The following is a description of a gene set: Human Gene Set: SFMBT1_TARGET_GENES Genes containing one or more binding sites for (SFMBT1) in their promoter regions (TSS -1000,+100 bp) as identified by GTRD version 20.06 ChIP-seq harmonization. species: Homo sapiens from publication Yevshin I, Sharipov R, Kolmykov S, Kondrakhin Y, Kolpakov F (PMID 30445619), and this is the list of marker genes: ENSG00000267174, SRP54-AS1, ACAD9, NARF, SPART, MMRN2, MTCL2, UCKL1, UCP2, NR2F1, AHCTF1, CERS5, ADD3-AS1, ATPAF2, NDUFS7, MDM2, DDIT4, DHRS13, RASSF8-AS1, SBF2, PTP4A1, TTC9C, ATF7-NPFF, PPP2R5E, GEMIN8P4, CLK3, IFT74, CACNA1A, TRIM27, PIP5K1A, EIF4G2, TNPO1, WDR25, NFKBIA (NFKB inhibitor alpha), DTX3L, AGPAT1 (1-acylglycerol-3-phosphate O-acyltransferase 1), VTI1B, SNORA50C, FRG1HP, FANCA (FA complementation group A), HIVEP1, TWSG1-DT, SNORA78, GLI3, TANGO6 (NCBI Gene Id 79613), GABPB1, GAN, PUM1, C2CD3, NTPCR, HSPA1L, AKAP9, HSPA1A, ZBTB21, PCNT, STK10, DIP2A, SNRPA1, ATP8B1-AS1, CRYZL2P-SEC16B, EPN1, COX5A, TMEM250, PYCR2, PIERCE2, UACA, RALGPS1, LINC01931, ALKBH5, BLOC1S5-TXNDC5, IST1, HDHD5-AS1, LUC7L2, COA4, CCPG1, STX18-AS1, CCNK, USP9X, UBC, BBS4 (NCBI Gene Id 585), AJUBA, MAP4K5, ASB7, NPHP3, CTSS, TNRC18, AP3B1, SIGLEC20P, FUT11, PPOX, KMT5B, PKN2, ZNF75D, PCF11, CDKN1B, MRPL54, VPS13D, SLC25A36, DHRS3, TCF12, MRPS15, ZNRF2, PPFIA2, CLDN7, SPRY2, ARL6IP1, ORAI1, LINC01600, EXD3, SLC35G2, HIF3A, PKM, RIF1, LAMTOR5-AS1, NFS1, ISG20, ZNF503-AS2 (NCBI Gene Id 283065), PALS1, FIRRM, WWTR1, HSPA5-DT, LINC01089, MID1IP1, TIA1, SELENOS, SNX30-DT, VAV2, IL6R, FRA10AC1, C14orf93, SVIL-AS1, ATXN7, PARD6A, GTPBP3, PRKCD, SF3B2, RPLP2, HINT3, GNPNAT1, SNORD95, FREM2, SMNDC1, PFKM, SON, MAU2, ATL1, OTULIN-DT, SPEN, AGAP2-AS1, ZFP91-CNTF, SEC61G, BLOC1S5, ZNF213-AS1, ANXA2, HINT1, MBD2, NR4A2, HOXC9, RCOR3, ENTR1, RN7SL329P, ZNF143-AS1, NDUFV3, KANSL2, NEO1, TMEM50B, SND1-DT (NCBI Gene Id 121832805), PIKFYVE, ENSG00000272473, VPS51, ZNF688, MAF1, IPMK, PHIP, SRP54, ITCH-AS1, ZBTB20, XPA, PDXK, TRIM23, GATAD2B, VAPA, KIF22, CSNK1G3, ZC3H7A, FRAT1, HEATR5A, AKR1C3, ARHGEF37, ZSWIM6, GSE1, NFE2L1, KCTD15, RAPGEF3 (NCBI Gene Id 27105), CT62, YIPF6, NSUN3, FAM228B, SNORD114-18, BEND6, PSMD9, STX16-NPEPL1, CCDC18, FEM1A, ECE1, PLEKHB2, ZRANB3, GFUS, LINS1, YY1AP1, HNRNPUL2-BSCL2, CDCA2, WASF1, NDUFB2, DLD, PDK1, SNORA48, SEC14L1, JPX, HSP90AA1, ABCC5-AS1 (NCBI Gene Id 100873982), SNORD35B, ENSG00000232732, SFR1, BANF1, DMXL2, MTARC1, CXXC5-AS1, EMBP1, POR, FOXP4-AS1, WDR4, CYREN, PHGDH, CARS2, NHLRC3, MFHAS1, SERP1, ARL2BP, TDRKH-AS1, TRIM2, THAP7, SQLE, COX6B1, DOLK, TIMM44, ELAC1, FOXP4, SLC35G1, ERBB3, CNOT10, SLC29A2, PIAS1, MFSD4B-DT, AQP3, SNHG15, TFB2M, SPTBN1, DPP8, RHOBTB1, SLC39A13, ZFAND3-DT, PON3, TMEM44, DOK1, DSCC1, RCCD1-AS1, SLC22A4, AP3B2, TPGS1, CDCA4, POLH, NFIA, INTS5, CIPC, SERPINB8, CPSF3, SERINC4, CKAP5, MAGI2, SSBP1, AKAP17A, PMF1 (NCBI Gene Id 94958), BCAN-AS2, ITGB3BP, PUS7, RIMKLB, ALG5, AFF4, PAAF1, SAAL1, TMED2, LINC03014, SYNM-AS1, THAP12, TGFB1I1, ATP1A1, RPL18A, DDX42, MFSD4B, ESRP2, VAC14, SMPDL3A, PARP1, ST20-MTHFS, EIF1B, DDAH2, SAPCD2, YTHDF2, TNPO1-DT, ASPSCR1, ERBB2, DNAJC13, PHF21A, SF3A3, XKR9, CCDC6, TMEM127, TMCC2, ECE2, CASP6, DNAJB14, PAN2, ARL6IP4, FBXO44, NEMP2-DT, ZNF142, FKBP7, LIN54, FURIN, RBM12B-DT, SNRPA1-DT, RGS3, KCNK15-AS1, SHTN1, FCHSD2, IL5, H1-4, THSD4, DDB1, USP47, WDR53, MRPL51, LINC01547, SQLE-DT, PSMB9, CEBPG, PIK3IP1-DT, LIPT2, ALKBH4, GFI1B, BRD4 (NCBI Gene Id 90616), MCL1, CFAP184, BLTP1, STARD7, CCDC97, MRPL38, TAX1BP1-AS1, ITGB5, PTPN9, AHNAK, GOLM2, TSEN15, ANKRD13A, SP4, SLC2A3P1, LCN8, NAXE, TTLL11, CAPRIN1, ACAP3, GOLGA4 (NCBI Gene Id 2803), NFE2L1-DT, VIM, CHERP, GALNT16-AS1, PBX3, CAP2, POLR1G, THOC1, SIAH2, CAPZB, IL23A (interleukin 23 subunit alpha), ASAP2, BNIP2, ATF6-DT, TFAM, TBC1D14, DHX16, PDCD4, SLX4IP, DNAL1, PWWP2A, PDE2A-AS1, UNC45A, EXTL2, MTBP, BRD3OS (NCBI Gene Id 266655), ADGRL1-AS1, TRMT11, OR4C10P, DOCK4, ADPGK, RNU6-942P, TP53BP2, MRPS2, SNX12, GNAL, FAM186A, ZFP91, MRPS23, CYP51A1, FBXL16, ART3, PPP2CA-DT, PDGFA, NUCKS1, LINC03015, OAZ1, NUDCD2, MICB, CTCF, NXF1, RPL5P34, TRAPPC13, FLAD1, SNHG7, SPTLC2, FAM217A, TANC1, SNHG9, ADRM1, FAM50B, PDCD6P1, ENSG00000273145, MEX3B, CROCC, MRPL17, FBXO9, SERTAD4-AS1, AK1, DTNB, EXOC2, CNOT1, ADM, PABIR1, PBX3-DT, INO80B, SLC9A3R1-AS1, CLNS1A, ZSCAN21, HYCC2, EPB41, YAP1, RNA5SP146, SGSM1, MBTD1, NDUFB5, ADAP2, DEFB1, SLC4A2, SNHG5, RPS26, ZNF326, ATG5, WDR11 (NCBI Gene Id 79207), CHSY1, HARS1, ETF1, CHD3, SETD4, SMAD3-DT, KCTD10, NDUFA8, CABLES1, MED10, HMGB1, LYPD8, TROAP, ADCY6-DT, NOXA1, PLIN3, ITPR1 (NCBI Gene Id 619543), SNORA40, NLRP11, MACF1, TOR1AIP1, GTF3C4, KLF2-DT, ING1, NAPEPLD, DNM1, FUT10, ELOF1, ADAMTS1, SORBS1, UBE2L5, RIOX1, CD55, KLHDC10, SNX33, VSIG10, MRPS30 (NCBI Gene Id 51331), SPRED1, HNRNPUL2, MSH5, VPS13C-DT, ZXDB, RANBP9, CEP63, HOXA6, CCNYL1, NUDT3, SSX2IP, NPL, PEX3, SNX30, HIPK3, TIPIN, LONRF3, DUOX1, ITFG1-AS1, TSR2, LINC01703, ZGPAT, KLHL24, CIZ1, GON7, PGAM5, ANTKMT, WDR36, NCK1-DT, TLK1, RICTOR, GALNT10, RGS6, SUMO2P20, ZNF436, ZC3H6, UBE2D3-AS1, EIF2D (NCBI Gene Id 1939), PCAT6, RAD9A, DGCR8, TOP3A, ADAT2, TTC33, CCDC57, NDUFAF6, GABPB1-AS1, PDCD6IP, F11R, EHBP1, ABCB9, EBP, ANKS1A, GVQW3, PPIC, SUN2, PPP1R13L, GABPB2, SEMA3A, MPHOSPH10, RAD51AP1, LRP6, GART, INTS1, SLC1A4, MAPK6-DT, CDC40, KCTD9 (potassium channel tetramerization domain containing 9), LIFR, IKBKB-DT, SERPINB6, LRP8-DT, ANP32E, EFCAB7 (EF-hand calcium binding domain 7), RHOV (NCBI Gene Id 171177), DDX31, HECW2, ANAPC13, TADA2B, POLR1F, AQP5, SEC23IP, DPY19L1, CYP39A1, EFNA1, ENO3, TCTN3, EXTL3, PIK3IP1, CBX3, MYO5A, OPHN1, C6orf62, TIGIT, YWHAQ, TMEM41B, ANGEL2, SKA2, ZNF131, SETD5 (SET domain containing 5), TUBGCP5, HPS5, SIX2, TLL1, SULT1A1, MLXIPL (NCBI Gene Id 51085), JAKMIP2, ATF7, DYRK3-AS1, PPP5D1P, C2CD2L, RN7SL197P, YARS1, KLRG1, CALML4, CUL4A, ZFPL1, E2F8, TBC1D13 (NCBI Gene Id 54662), SPHK1, PHTF2, ZFP36, CSNK1A1L, ZBTB9, DCXR, CLIC1, NUP214, MIR31, MIRLET7IHG, ZNF160, SH3RF2, LINC00857, NSUN2, WDR35, CCDC88A, FBXW11, UGGT1, TAF11, RFX7, MRPS7, CDKN1C, POLR1H, ABCD4, UNC5B, LINC01836, SLX9, ALAS1, GMEB2, APBA3, CAV1, KANSL1, SYNM, AGO3, TP53I3, ID3, LINC02084, SUGCT, RSRC1, NEPNP, ATP1B1, ENSG00000237773, NUP188, BMF, SERPINI2, PTEN, PTBP1, METTL16, VGLL4, STT3B, CCNO-DT, CCDC32, PACSIN3, METTL8, MRPL55, CAPZA1, TACO1, HMMR, E4F1, TMPPE, NETO2, FAM98B, PLAG1, FOXJ3, ENDOV, KPNB1-DT, DNTTIP2, MOV10, INHBA, PFN2, ANTXR1, GRAMD4, S100A16, GGA3, EIF4ENIF1, AURKAIP1, ZNF277, WDR35-DT, NSMAF, SNHG25, TINAGL1, NPR3, EIF4A2, FERRY3, RPS2, AJUBA-DT, TMCO1, FASTKD3, TMTC3, RNF207-AS1, FZD10-AS1, PPME1, RNU7-13P, BOLA3-DT, HNRNPF, MUS81, MEIS1 (Meis homeobox 1), CDK5, H2AC20, DHFR2, ZNF451, GTF3C3, ZNRF2P1 (NCBI Gene Id 441208), RPUSD2, KANSL1-AS1, UBE2D2, CMSS1, PRKCZ, SEPTIN2, GATA6, SLTM, FSCN1, GEMIN8, UROS, ANAPC5, LINC01588, PIR, MAP3K3, EIF1B-AS1, CTNNB1, RAB14, AMACR, DUSP5, GALE, BHLHE40, ANAPC11, DHCR24-DT, CACYBP, HUS1, MIR4512, CGGBP1, SLCO4A1-AS1, RNF4, HGSNAT, VDAC1 (NCBI Gene Id 7416), CDC42EP4, PUS1, OSGIN2, MUCL3, SYNGAP1-AS1, SLC25A27, CSTF3-DT, GINS3, COTL1, MT2A, MCFD2, SOX7-AS1, CHD2, UTP14A, DHFRP2, HCFC1R1, MID1IP1-AS1, HNRNPLL, SNRPE, COMMD6, FKBP8, USP3, SS18L2, TPMT, ADNP (activity dependent neuroprotector homeobox, NCBI Gene Id 256440), SUGP1, ATL3, RACK1, HSPA5, PGBD2, H2AZ2-DT, ARPC5L, SLC2A4RG, H1-10, ZFAT, GUCD1, UAP1-DT, CTNNBL1, SLC25A39, ABLIM3, ZFAND6, SLC7A6, FAM162A, CNOT7, RN7SL862P, SIN3A (NCBI Gene Id 25942), MIR3137, ADCY7, PI4K2A, ZMPSTE24, POLD3, FZD10, WNT2B, TMC1, PER1, POLR3B, ZNF639, GLB1, CCNE2, CACTIN, GTF2H1, SMAD3, ARHGAP5-AS1, CHCHD7, MTHFD2L, EIF5B, FAM3C, H2BC4, RNU6-21P, TNFSF13, ARHGAP28-AS1, SLC39A14, SCAMP1, DNA2 (DNA replication helicase/nuclease 2), HADH, SECISBP2L, PPP2R5A, CALM1, TMCO4, ZC3H12A, UBR7, NFIB, HOXA13, ABCA2, RRM2, ZIC2, MIR17HG, STARD4, RBIS, RPS7, DAXX (death domain associated protein), SLMAP (NCBI Gene Id 7871), C2orf76, TMEM170A, CYP4F3, WWTR1-AS1, SCAF4, TRIM52, STX16, MSLN, POFUT1, TMX3, ST6GALNAC2, COMMD2, COL4A3, SH3BGRL3, HMOX1, GK5, OSCP1, PHF8, MAPK1IP1L, ST7L, RBM12B, CD2BP2, MIR3661, GTF2I, SERTAD1, DPY19L4, OGT, ARHGAP21 (NCBI Gene Id 57584), KLHL20, HIGD1AP5, ARL2, RBPJ, LEMD2, ZCCHC2, TDRKH, CALU, XK, RNU7-152P, HIRA, ZBTB49, CDH3, APAF1, NIPAL1, FUNDC1, MAIP1, HEATR5A-DT, ENSG00000254718, SUN1, WWC2, PEAK1, MIX23, ZFAND3 (zinc finger AN1-type containing 3), C16orf95-DT, DCXR-DT, API5, SLC39A3, TNC, CISD1, LZIC, MPV17, MEMO1, SYP, LDB1, CLP1, DAP3, GAA (alpha glucosidase), LSR, NUCB2, PDE3A-AS1, SHLD3, CYP4V2, LPXN, NELFA, TFAP4, ELP6, ARB2A, TCF25, UBAP2L, TRIO, ETV5, TRMO, TAF15, TSC1, NEDD1, ZNF367, TICAM1, FOXC2, HMGXB3, RBP4, PIERCE1, VGF, IMP4, SDCCAG8, MRAS, WDR11-DT, H4C16, TPM2, C1GALT1P1, SLC27A3, APBB3, ASF1B, TRIM47, BCAR3, NPR1, CENPBD2P, C9orf78, TADA2A, HSD17B1-AS1, GATM, SARAF, SNX9, SNAPIN, LRRC1, AGPAT3, MUC19, THUMPD3-AS1, EHD4, OXCT1-AS1, IDH1, RIMOC1, RNF207, ALYREF, HNRNPH3, KLHL29, BRPF1, MAGEF1, DOP1A, ATF6, RBM39, TMEM222, MPI, EXOC3-AS1, MIR5585, FHL1, EGR1, BRWD1, RLIG1, UBE2Q2, SRP9, GAPDH, ZDHHC16, NAA15, ID2, ACAA2, STAT5A, LINC01686, SS18, RPL35, XPO7 (exportin 7), PDZD2, ATP5MGP8, NOD1, UTP18, KYAT1, HTR1A, NCOA4, PLCXD2, MRPL40, YWHAZ, DUSP5-DT, PSMC3, RGL1, GAPDH-DT, GMNN, RAB10, INHBA-AS1, ARHGAP5, IKBKB, HNRNPR, ALDH3B1, NARF-AS2, LSM6, CBLL1 (NCBI Gene Id 79872), TCHP, RXRA, CCDC102B, BICD2, SMG7, THRB-AS1, PCDH9, FAM136A, ZMPSTE24-DT, EMP1, DST, CEP290, MIR4289, EXD2 (NCBI Gene Id 55218), SNAPC5, MGA, CASP2, ZNF205, SND1, GPNMB, KAZALD1, FLJ38576, ENSG00000266401, MED25, CDH6, C5orf22, CNN2 (NCBI Gene Id 1265), VAV3-AS1, RINT1, ID2-AS1, ARFRP1, SOAT1, SLC38A1, RAB11FIP3, ANKRD46, ALG3 (ALG3 alpha-1,3- mannosyltransferase), MCEE, ALG10B, MCAM, MOGS, TAF13, CIMAP1B, ATG12, TM2D3, DONSON, TFAP2A, ARL3, NDUFC2, ARHGEF2, TMEM179B, CD2BP2-DT (NCBI Gene Id 101928707), ATP2B1-AS1, DRAM1, ANXA2R-AS1, WDR45B, ZNF627, DPP9, ASAH2B, SLC45A4, WARS1 (NCBI Gene Id 7453), P2RY6, TNIK, FBF1, SMAD6, OARD1, NDUFC2-KCTD14, DPYSL2, SNORD12C, TTC24, KPNB1, KIF1B, CCDC150, FBXO43, AAAS, PCM1, ATF6B, MTRR, SEC22A, SLC33A1, RAET1E-AS1, CSNK1D, SLC19A2, YAF2, DYSF, MIR4749, FIBCD1, ROCK2, TFAP2A-AS1, MRPS14, KNTC1, PPM1A, CDC42SE1, ASS1, GDPD5 (glycerophosphodiester phosphodiesterase domain containing 5), DNAJC4, ACAP2, UTS2B, KIF26A (NCBI Gene Id 26153), SLC22A15, PLXND1, NLRP10, UBXN2B, ZNF695, EML6, PIK3AP1, ST20, HOTTIP, PLCD3, PRSS21, KIFC2, PARAIL, BCCIP, DUSP6, PNRC1, KDM6B, RAD23B, TMC5, CBR3-AS1 (NCBI Gene Id 100509048), RGS13, UBE3B, GADD45GIP1, MCCC1, MAP4K3, H2AZ1-DT, ZNF823, CETN4P, MZF1-AS1, PER3, POLR1HASP, COPS5, MIR3621, AP3S1, ZNF503, CBX4, FBXO45, ZNF696, PRDX1, SNORD104, CABLES2, STX6, PEX26, CFAP418, TMEM19, DNAJC9-AS1, HYOU1, SDHAP3 (NCBI Gene Id 731488), ANKRD13B, S100A10 (S100 calcium binding protein A10), ODAD3, SH2D4A, TKFC, CMC1, NCOA3, PLSCR1, USP8, CCDC82, NIPBL, EIF4B, C7orf25, LRWD1, C17orf75, MIR4458HG, MZT2B, MIR1915HG, CASKIN2, MKKS, RNF169, NRIP1, STAT1, SH3BP2, RAF1, SMPD4, HCG27, ZNF79, ZNFX1, CDK12, MGME1, PTRH1, SNORD114-19, LBX1-AS1, TFEB, H2BC7, CORO7, PCNX4, ENSG00000263011, BRINP3 (BMP/retinoic acid inducible neural specific 3), PGAP3, SUB1 (NCBI Gene Id 10923), ALG10, MAP4K3-DT, HEXIM2, TXLNG, TP53I13, WBP4, DROSHA, DPH7, LYSMD4, HEXIM2-AS1, STARD4-AS1 (STARD4 antisense RNA 1), C1QTNF1-AS1 (C1QTNF1 antisense RNA 1), ZDHHC23, SUCO, SPART-AS1, LAMTOR5 (NCBI Gene Id 10542), SLC41A1, ERAP2, TRERF1, TIPARP, DEGS1, NTMT1, KIAA0825, PPP6R2, EIF1AD, LINC02868, PTBP3, ENSG00000223343, PUSL1, LRSAM1, AQP5-AS1, LINC01842, RGS2, ATP13A2, HARS2, NREP, SNHG28, TMED5, AMBRA1, IFI6, MATCAP2, SNX7, PRPF19-DT, EXOSC1, MAPK6, TAP1, IL1RAP, CEP68, POP4, SLC25A4, SLC25A20 (NCBI Gene Id 788), CTTN, R3HDM1, FCHO2, SLPI (NCBI Gene Id 6590), SLC35C1, RN7SL181P, C15orf32, ANO10, OTULIN, TENT4A, NOP16, SRBD1, PIGU, CNGA1, MZF1, TUSC2, ZFAND5, NDUFC1, PIGH, RNF216, H2AZ1, GALNT18, TSKU-AS1 (NCBI Gene Id 101928837), BMPR1A, PRKCZ-DT, LRPPRC, SYT17, MCMBP, TRA2B (NCBI Gene Id 6434), ZDHHC5, VEZT, OGDH, TPRA1 (NCBI Gene Id 63108), SLC11A2, MAD1L1, WDR41, FLYWCH1, IL19, WEE2-AS1, ITGB1BP1, TMEM39A, SLF1, AP5S1, TEFM, COPZ1, GCNT1P2, ZNF34, PLK3, CYP2E1, EIF2A, RNU6-2, POLA1, LMBR1, ACD, PABPC1, CALM3, MIR5188, SLCO4A1, ADAM17, VPS13C, LINC02418, DUSP12, HMG20A, CAMSAP2, RHOF, CNPPD1, CELF1, STRBP, GNB2, C6orf89, ACTN3, EBLN3P, COX19, TIPARP-AS1, LUC7L, MEIS2, GPHN, RESF1, CDKL5, EIF3F, EPHA2-AS1, NEAT1, MED30, GAS1RR, LYVE1, EPB41L4B (NCBI Gene Id 87974), ROMO1, RIPK1, TYW5, GPAT3, BCS1L, COG2, CEP170, SOCS2, AZIN1, PPP1R3D, CNOT6, SRSF9, CEMIP2, PDE8A, NAPG, LIPT2-AS1, ATP5F1A, MEF2A, CSTF3, TAF4B, CEP120, CDC42BPG, SPPL2A, BICDL1, NCAPD2, TSKU, TNRC6A, ZNF195, PDE2A, PPP2CA, TAF1D, CCDC115, SH3RF1, USP20, CNIH1, FRS3, ARHGEF3, SNORD63, JPT1, TPT1P5, METTL15, DMAP1, GPT2, ANLN, HMGN3, U2SURP, ZNF280D, BCL2L13, METTL18, ZMIZ1, SAMD11, TSEN54, PCBP1-AS1, MAFK, THAP5P1, TRPM7, DENND4B, DHCR24, DDX18, CEP55, BEST2, C2orf42, HMGA1, MED4, ATP5MJ, NAXD, TMEM60, ENSG00000268129, DDX6, SASS6, RFK, GCHFR, UGGT2, EIF4A1, P4HTM, ATG3, C3orf33, NUDT18, SPATS2, TOR4A, PEBP4, LRRC8A, ZNF143, MRPL1, CA13, LRP12, RGS19, MRGBP, ZNF449, TGDS, ATXN1, BEND3 (NCBI Gene Id 57673), PTOV1, ARHGAP26 (Rho GTPase activating protein 26), TMEM259, SMAD7, NPHP3-AS1, DPAGT1, PCID2, ARL2-SNX15, ADAMTSL4-AS1 (NCBI Gene Id 574406), COQ8A, LINC03067, CDCA5, RCN2, NEGR1 (neuronal growth regulator 1), ELOVL6, ZNF436-AS1, SCLY, ZDHHC24, ADM-DT, SEC13, FXN, QSOX1, TDRD7, REX1BD (NCBI Gene Id 55049), PPP1R37, SCAMP5, PMF1-BGLAP, PARP2, SMIM13, NF1P6 (NCBI Gene Id 644637), STIP1, BCAS2, PDCD4-AS1, SLC35A4, RAB11FIP1, G6PC3, RNASEH2C, DHX9, PRR11, M6PR, CXXC5, SNRPD3, ZFAS1, LFNG, C1orf43, ACBD6, LRRN4, SIPA1L1, SEMA4A, KIFC3, PROSER1, IFT20, EXOC5, WDR89, CORO1C, SSB, SLC35A5, PTPN18, DYNLL1, PLD3, BTBD10, SETD3, SMAD5, PIDD1, PRKCSH, BMS1, PIM3, CSNK1E, HRK, FBXL7, ZNF18, TMEM243, ALDH1A2, ALG9, SLC44A1, FGF9 (fibroblast growth factor 9), DAG1, DCAF17, CSNK1A1, RNF41, TUT7, KLC2, USPL1, ATAD2, VHL, GYG1, PYCR1, ZNF280B, RAD50, EAPP, XPO5, CDC42SE2, HOXB6, PLAA, EIF3A, TRMT13, WDR31, LPCAT1, LRRC23, NDRG1, HEG1, SEPTIN9, CEP295, TOMM6, MALINC1, IKBKG, PLAAT3, LINC02324, RWDD1, AP5M1, LNPEP, PAFAH2, DRG2, DBI, SLC4A5, MRPL13, PCDHB1, PPP2CB, FBXO24, ATP6V1E1, PLK2, MTF2, PARP6, PPARG, FGD6, H2AC7, AFF4-DT, ZFX-AS1, KCNQ5, KDM1B, SHARPIN, MIR1915, ZNF268, MGST3 (NCBI Gene Id 9272), DAAM1, ZNF76, ENO1P1, TSR3, IPPK, BBS12, DNAH11, OPRL1, FBXO2, LRG1, HUWE1 (NCBI Gene Id 54789), CORO7-PAM16, INO80B-WBP1, USP36, CNEP1R1, RNU6ATAC, CYB5R3, NR2F2, CREBZF, KCNJ6, LINC02226, UBE2M, PDE3A, B3GLCT, ZFX, FANCL, H2BC26, ATP1B3, NEMP2, CBFA2T2, PLA2G4E-AS1, XXYLT1, MAST1, C20orf181, TNFAIP1, LINC00322, PDXDC1, CFAP54, MHENCR, CAT, MAP3K5, SETD4-AS1, CNST, YY1, SIAH2-AS1, FBRS, FOXO3, MRPL47, CYP1B1, PRKAB2, SRD5A1 (steroid 5 alpha-reductase 1), ARHGAP28, UBTD1, RETREG2, FAM217B, KANSL1L, LINC02934, AP3D1, ZER1, PCDH7, PMPCA, CSPP1, P3H1, KANK2, BIRC3, PJA2, ESR2, MRPS30-DT, PRC1, APPL1, PPCDC, MPIG6B, MPLKIP, GNAI2, CFAP20, CCAR2 (cell cycle and apoptosis regulator 2), SLC38A2, VAV3, SSBP2, RNVU1-7, LRP4-AS1, TRIM45, RFX1, RPS9, B4GALT4 (beta-1,4-galactosyltransferase 4), IKBIP, TYMS, TMEM135, NDUFB3, ELF2, TMEM198B, FAM133B, CAST, VPS37A, USP54, NMNAT1, SFXN2, ANXA2R, STX18, MIER1, BEGAIN, EYA4, CARNMT1, NOL4L, SPTAN1, RCCD1, RABEPK, UBE2D3, PIWIL2-DT, DCTPP1, STEAP2-AS1 (STEAP2 antisense RNA 1), C2CD5, KCTD6